The following is a description of a gene set: A multisubunit complex that catalyzes the acetylation of histones H4 and H2A. studied in species Mus musculus Mouse Gene Set: GOCC_H4_H2A_HISTONE_ACETYLTRANSFERASE_COMPLEX, and this is the list of marker genes: Dmap1, Vps72, Brd8, Epc1, Actbl2, Ruvbl1, Ep400, Yeats2, Meaf6, Yeats4, Morf4l1, Ing3 (NCBI Gene Id 71777), Actb, Trrap, Actl6b, Msl3, Morf4l2 (NCBI Gene Id 71961), Acte1, Msl3l2, Actg1, Kat5, Brd8dc, Ruvbl2, Epc2, Actl6a, Mbtd1, Kat8, Mrgbp